Given this list of marker genes Myef2, Enpp1, Fcrla, Ddx51, Cryaa, Lmo4, Pira1, Sars1, Gzme, Trim46, H2-Ab1 (NCBI Gene Id 406212), Socs1, Samd10, Tirap, Rras, Atp6v1a, Tax1bp3, Pim2, Kin, Cacnb3, Gzmd, Ptpra, Sec62 (SEC62 homolog, preprotein translocation), Gap43, Hdac5, Pi4kb, Kif23, Rhoh, Fzd7, Myl4, here is a description of the gene set: Genes up-regulated during differentiation from pre-BI to large pre-BII lymphocyte. Gene expression profiles of five consecutive stages of mouse B cell development were generated with high-density oligonucleotide arrays from as few as 2 x 10(4) ex vivo isolated and flow-cytometrically purified cells. Between 2.8% and 6.8% of all genes change on differentiation from one cellular stage to the next by at least twofold. The entire pathway involves differential expression of 10.7% of all genes. Previously known expression patterns of genes (like surrogate light chain, RAG-1/2, MHC class II, mel-14 antigen) are confirmed. The gene expression patterns of the proliferating pre-BI and large pre-BII cells on the one hand, and the resting immature and mature B cells on the other hand, are most similar to each other. Small pre-BII cells display a pattern that is transitional between these two groups. Most of the genes expressed in early precursors are involved in general processes, like protein folding or cell cycle regulation, whereas more mature precursors express genes involved in more specific molecular programs (cell surface receptors, secreted factors, and adhesion molecules, among others). Between 19 and genes share a given expression pattern. Combining knowledge about gene function and expression pattern allows identification of novel candidate genes potentially involved in self-maintenance of pre-BI cells, allelic exclusion and pre-B cell receptor signaling in large pre BII cells, cell-cycle arrest of small pre-BII cells, propensity toward apoptosis or anergization in immature B cells, propensity toward cell division and activation in mature B cells, and stage-specific interactions with stromal cells in the bone marrow. Mouse Gene Set: HOFFMANN_PRE_BI_TO_LARGE_PRE_BII_LYMPHOCYTE_UP studied in species Mus musculus from publication Hoffmann R, Seidl T, Neeb M, Rolink A, Melchers F (PMID 11779835)